Given this list of marker genes Entpd5, Entpd4, Entpd1, Entpd6, Entpd4b, here is a description of the gene set: Mouse Gene Set: GOMF_CDP_PHOSPHATASE_ACTIVITY Catalysis of the reaction: CDP + H2O = CMP + phosphate. studied in species Mus musculus